The following is a description of a gene set: Human Gene Set: HP_ORTHOKERATOTIC_HYPERKERATOSIS studied in species Homo sapiens Orthokeratotic hyperkeratosis A form of hyperkeratosis characterized by thickening of the cornified layer without retained nuclei., and this is the list of marker genes: RSPO1, CFTR, SULT2B1, DSG1, KRT10, PNPLA1, SERPINB7